The following is a description of a gene set: Reactome Pathway: CHD chromatin remodelers part of: ATP-dependent chromatin remodelers electronically inferred by orthology from the curated human pathway This event has been computationally inferred from an event that has been demonstrated in another species.<p>The inference is based on the homology mapping from PANTHER. Briefly, reactions for which all involved PhysicalEntities (in input, output and catalyst) have a mapped orthologue/paralogue (for complexes at least 75% of components must have a mapping) are inferred to the other species. species: Mus musculus, and this is the list of marker genes: Chd8, H2bc1, H2bc3, H2bc15, Rbbp4, H2ax, H2bc9, H3c13, H2ac4, Mta1, Rbbp7, H2bc7, Mbd3, Mbd2, H4c3, H4c8, H2bc22, Sumo1, H4c17, H4c2, H3c15, H3c6, H2ac10, H2ac12, H4c14, H3c8, H3c4, H2az2, H3c2, H2ac1, H2ac8, H3c1, H2ac13 (H2A clustered histone 13), Fam124b, H4c1, H3c3, Mta2, H2ac22, H2bc27, H3f3a, H3c7, H4c12, H2bc11, H3c10, Nr2c2, H2ac11, H3c11, H2bc13, Mbd3l2, Zfp532, H4c6, Ctnnb1, H4c11, H2ac15, Pwwp2a, H2bc8, H2bc12, H2ac6, H4c9, Zfp687, H2ac7, H2ac19, H2ac23 (H2A clustered histone 23), H2ac24 (H2A clustered histone 24), H4c18, H4c4 (NCBI Gene Id 319156), H2ac20